Given this list of marker genes Eogt, Abo, 4930402F06Rik, Glt6d1, Pgap4, Extl3, St6galnac1, Mgat1, Galnt9, Alg12, Xylt2 (xylosyltransferase II), B3gnt3, Xxylt1, Pygm, Tmtc4, Cercam (cerebral endothelial cell adhesion molecule), Tymp, Fut9, Agl, Pigq, Fut8, B4galt1 (NCBI Gene Id 99960), Mgat4b, Pnp, St6galnac5, Pigz, B3gnt8, Ugt1a10, Hprt1, Has2, Uggt1, Alg1, St3gal1, Gyg1, St3gal2, A4galt, B3gat2, B3galt9, B3galt6, Galnt14, Pofut2, Gys2, Glt1d1, B4galnt1, Gba1, Ogt, Gcnt7, St6galnac3, Ugt2b37, B3gnt9, Parp10, Parp12, Ggta1, B3gnt5, Galnt17, Chsy3, Stt3b, Rxylt1, Alg11, Galnt11, Hexb, Colgalt2, Alg2, Tmem260, Chsy1, B3gat3, Alg10b, Ugt2b1, Has1, Gcnt2, Ugt8a, B3gntl1, B3galnt1, Dpm2, Mgat4a, Galnt3, 4930568D16Rik, Ugt1a8, Alg8, Mgat5b, Galnt6, Mfng, Dpm1, Tiparp, Pigyl, Ext1, Gys1, Tnks2, Gbgt1, Gbe1, Uggt2, Ugt2a2, Pomt1, Pigp, Fut4, B3gnt6, Galnt10, Parp2 (NCBI Gene Id 30876), Ext2, Tmtc1 (NCBI Gene Id 387314), Wdfy3, Dpy19l2, Ugt2a3, Ugt1a2, Alg5, Art2b, Chpf, Extl1, B3gnt4, Parp3 (NCBI Gene Id 320721), Qtrt2, Csgalnact1, Parp6, St3gal6, B4galt5, Upp1, Alg3, Hexa, Parp9, Pygb (NCBI Gene Id 207396), C1galt1c1, Ugt1a5, Mgat4f, Dpy19l4, B3galt5, Ppat, Sirt4, St8sia5, Gtdc1, Glt8d1, St3gal4, B3gat1, Upp2, Ugt1a7c, B4galt6, Alg9, St6galnac4, Large2, B3galt1, B3gnt7 (NCBI Gene Id 329198), Sirt2, Lacc1, Gba2, Lalba, Chpf2, Ugt3a2, Alg6 (NCBI Gene Id 320438), St8sia2, B4galt7, Tmtc3, Alg13, Ugt2b36, Mgat4e, Pofut1, Csgalnact2, Extl2, Galnt1 (NCBI Gene Id 14423), Gcnt3, St6galnac2, Piga, St3gal5, B4gat1, Ugt2b38, Galnt5, Mgat4d, Art5 (NCBI Gene Id 11875), B3galnt2, Parp14, Ugt1a6b, Sec1, Pygl, B4galt2, Galntl5, St8sia3, 6430550D23Rik, Galnt13, Galnt16, St6galnac6, Aprt, Lfng, Art2a (ADP-ribosyltransferase 2a), Fut2, Art3, Galnt4, Galntl6, Epm2a, St8sia1, Mgat4c, St3gal3, Gxylt1, B3glct, Zc3hav1, Poglut2, Arl6, Gcnt1, Ugt3a1, B3gnt2, Dpagt1, B3galt2, Parp8, Fut7, Potefam3a, Poglut1, Art1, B4galnt4, Pomt2 (protein-O-mannosyltransferase 2), Parp11, Qtrt1, B4galnt2, Parp16, Pigm, Gcnt4, Galnt7, Fut11, St6gal1, Nampt, Potefam3b, Qprt, Gxylt2, Galnt15, A3galt2, Parp1, Galnt18, Ugt1a9, Xylt1, Pnp2, Galnt12, Ugcg, Pigb, Poglut3, Mtap, Tmtc2, Has3, Dpy19l1, Ugt2a1, Mgat3 (mannoside acetylglucosaminyltransferase 3), Galnt2, Fut1, Umps, Mgat5, Sirt6, Ugt1a6a, Ugt2b5, Large1, Colgalt1, C1galt1, Ugt1a1, Glt8d2, Pomgnt1, Pomgnt2, Ugt2b35, B4galnt3 (NCBI Gene Id 330406), St6gal2, Stt3a (NCBI Gene Id 16430), A4gnt, Plod3, Arf4, Hyal1, Ugt2b34, B4galt3, B3galt4, B4galt4, Pigv, Parp4, St8sia4, Rfng, St8sia6, Art4, Tnks, Fut10, Mgat2, Dpy19l3, Ankrd66, here is a description of the gene set: Catalysis of the transfer of a glycosyl group from one compound (donor) to another (acceptor). Mouse Gene Set: GOMF_GLYCOSYLTRANSFERASE_ACTIVITY studied in species Mus musculus